The following is a description of a gene set: A developmental process, independent of morphogenetic (shape) change, that is required for the central nervous system to attain its fully functional state. The central nervous system is the core nervous system that serves an integrating and coordinating function. In vertebrates it consists of the brain and spinal cord. In those invertebrates with a central nervous system it typically consists of a brain, cerebral ganglia and a nerve cord. species: Mus musculus Mouse Gene Set: GOBP_CENTRAL_NERVOUS_SYSTEM_MATURATION, and this is the list of marker genes: Arcn1, Grin1, Cend1, Cx3cr1, Cdk5r2, Cacna1a (NCBI Gene Id 12286), Atp6ap2 (NCBI Gene Id 70495), Cdk5r1, Rere